Given this list of marker genes PRDM16, PRKCZ, B3GAT3, DDR2, FOXI1, ROR2, NFIX, GRIP1, DACT1, RSPRY1 (ring finger and SPRY domain containing 1), CENPJ, FANCF, KCTD1, POMT2, KMT2D, RSPO2, LAS1L (LAS1 like ribosome biogenesis factor), ZMYM2, SF3B2, SEMA3E, CHD7, WDR73, PAM16, RPL27, FANCB, GNAI3, RPL8, RIC1, RPS17, TSR2, FOXP2, NUP107, SIAH1, TBX4, NELFA, RIPK4 (receptor interacting serine/threonine kinase 4), EFTUD2, TP53RK, POLA1, UBAP2L, UFC1, DLK1, HEATR3, RPL15 (ribosomal protein L15), AGA, EIF5A, SLF2, ITGA6, POLR1B, STAG2, DDX3X, GATA1, WDR4, RPS10, NSD2, SKIC3, PCGF2, RPS28, AHDC1, CTBP1, FBXO11, MMP23B, LMNA, RPS24, U2AF2, HSPG2, HOXA2, ADA2, PRIM1, MED12, RPS26, TCOF1, TBX15, BMP2, FIG4, PSMD12, RPL31, ATRX, RPS29, CD96, CDC45, RPS20, RAB34, EDNRA (NCBI Gene Id 1909), CDT1, FKTN, LUZP1, GREB1L, RPL35, KCNAB2, TWIST1, WNT3, MEG3, ITGB4, HIVEP2, UQCRH, RNU4ATAC, CAMK2A (calcium/calmodulin dependent protein kinase II alpha), LMBRD1, FGF10, FGF3, GABRD, DBR1, MAPRE2, SLC26A4, FOXI3, PIGN, MAF, MCM5, FGFR3, ADNP, CPLX1, KIF15, TFAP2A, FANCL, CTCF, OSGEP, SETD1A, PLEC, SIM1, FREM2, POC1A, MAN2C1, RPS19, PAK1, B3GLCT, HOXA13, CHST3, ACTB, CDC6, INTU, PLCB4, KCNJ10, DCHS1 (dachsous cadherin-related 1), FKRP, SPOP, GON7, FAT4, SLC35C1, EDN1, POLR1D, FRAS1, HDAC8, KDM6A, CNOT1, ORC4, RPL5, ORC6, CASZ1, ZNF462, RPL26, RBM10, RERE, ABHD5, NIN, DHODH, TWIST2, UBE4B, SALL1, SMAD4, HECTD4, GMNN, RPL9, PBX1, EYA1, SKI, SIX5, COG1, ORC1, FGFR2, HS6ST2, POLR1C, CRPPA, PCNT, YRDC, SIX1, OTUD6B, HNRNPK, RPS27, MAP1B, ERI1, LETM1, LARGE1, POMT1, RTL1 (NCBI Gene Id 651665), RPL35A, CHD5 (NCBI Gene Id 26139), GLI3, NEUROG1, MBD5, POLR1A, DDX11, EIF4A2, HSPA9, PDPN, RPL11, TAF4, NUP133, RPL18, WBP4, MSX2, SF3B4, LAGE3, TCTN3, RPS15A, GBA1, PIGG, AMER1 (APC membrane recruitment protein 1, NCBI Gene Id 160176), BPTF, TPRKB, POLE, TP63, RPS7, PIK3CA (phosphatidylinositol-4,5-bisphosphate 3-kinase catalytic subunit alpha), RECQL, SPEN, here is a description of the gene set: species: Homo sapiens Aplasia/Hypoplasia of the ear Human Gene Set: HP_APLASIA_HYPOPLASIA_OF_THE_EAR The presence of aplasia or developmental hypoplasia of the ear.